The following is a description of a gene set: Deregulation of Ras pathways results in complex abnormalities of multiple signaling cascades that contribute to human malignancies. Ras is therefore considered an appropriate target for cancer therapy. In light of the complexity of the deregulated Ras pathway, it is important to decipher at the molecular level the response of cancer cells to Ras inhibitors that would reregulate it. In the present study, we used gene expression profiling as a robust method for the global dissection of gene expression alterations that resulted from treatment with the Ras inhibitor S-farnesylthiosalicylic acid (FTS; salirasib). Use of a ranking-based procedure, combined with functional analysis and promoter sequence analysis, enabled us to decipher the common and most prominent patterns of the transcriptional response of five different human cancer cell lines to FTS. Remarkably, the analysis identified a distinctive core transcriptional response to FTS that was common to all cancer cell lines tested. This signature fits well to a recently described deregulated Ras pathway signature that predicted sensitivity to FTS. Taken together, these studies provide strong support for the conclusion that FTS specifically reregulates defective Ras pathways in human tumor cells. Ras pathway reregulation by FTS was manifested by repression of E2F-regulated and NF-Y-regulated genes and of the transcription factor FOS (all of which control cell proliferation), repression of survivin expression (which blocks apoptosis), and induction of activating transcription factor-regulated and Bach2-regulated genes (which participate in translation and stress responses). Our results suggest that cancer patients with deregulated Ras pathway tumors might benefit from FTS treatment. Selected genes up-regulated in response to the Ras inhibitor salirasib in a panel of cancer cell lines with constantly active HRAS. studied in species Homo sapiens from publication Blum R, Elkon R, Yaari S, Zundelevich A, Jacob-Hirsch J, Rechavi G, Shamir R, Kloog Y (PMID 17409441) Human Gene Set: BLUM_RESPONSE_TO_SALIRASIB_UP, and this is the list of marker genes: CXCL3, LAPTM4A, EIF5, HYOU1, IL6, RSL24D1, EIF1, MARS1, TESK1, VIM, DPAGT1 (NCBI Gene Id 1799), ZYX, ZPR1, TCEA1, RELB, HOXA1, CASP4, OGT, FST, ULBP1, SCFD1, NSMAF, TOM1L1, PPIE, FEM1B, CD55, TNFAIP3, RAB5A, CSTA, ARHGEF2, YKT6, CDK13, ATF6, TMBIM6, ACVR1, RAD23A, KRT34, SLC35A2, ZNF593, SSR3, CEBPG, LRP1, ERCC1, UBXN1, ISG20, RAB22A, XPC, CCNB1IP1, MGAT1, HSPA9, GADD45A, SEPHS2, NAPG, NAMPT (NCBI Gene Id 10135), COPA, HSPA13, NINJ1, INPP1, BACH1, BAK1 (NCBI Gene Id 578), EIF2S2, NARS1, MDM4, HSP90B1, NOP53, MAP1LC3B, SQSTM1, CSNK1G1, UNG, HMGCL, DNAJA3, TIMM44, EEF2, CBLB, KPNA5, APBA3, SGPL1, PHGDH, AARS1, RELA, RNF7, POLI, STC2, TBL1X, RPL12, UBE2H, CALU, CANX, TOM1, ZFPL1, RAB32, NDEL1, BCL2L1, KCMF1, PSEN1, IFRD1, RIOK3, SLC1A5, STX4, SARS1, EIF4EBP1, CBX4, P4HB, COX7A2L, SERPINB8, SERP1, GOLGA5, GOLGB1, NUPR1, SLC33A1, GOT1, CNIH1, MTHFD2, CDKN1A, NIT1, CTSL (NCBI Gene Id 1514), EIF1B, GLG1 (NCBI Gene Id 2734), TARS1, GFPT1, NFKBIA, SCAMP2, ESRRA, RALA, ATF5, FAM3A, PPP1R11, TMED3, RAB33A, MTIF2, TP53, PPP2R5B (NCBI Gene Id 5526), CTH, RRAGC, STAM2, BCAT1, MKNK2, ENTPD6 (NCBI Gene Id 955), QSOX1, FOSL1, GOSR2 (golgi SNAP receptor complex member 2), TP53BP2, SIAH1, DAP3, XPOT, VPS28, SPHK1, USP3, ECH1, KLF11, SEC63, SIAH2, LIPT1, MYO5A, ERP29, TNFRSF10B, CBS, AVEN, GTPBP2, PSMD8 (NCBI Gene Id 5714), CREB3, COX10, COG5, BTG1, TSG101, TRIB3, STK19, EPRS1, DNAJC1, BUD31, PEA15, CTSD, PSAT1, EIF3H, PKD1, WARS1, TIMM9 (translocase of inner mitochondrial membrane 9), AZI2, CSNK1A1, IL12A, SUPV3L1, ASNS (asparagine synthetase (glutamine-hydrolyzing)), ACBD3, RRN3, MMP10, SURF1, PJA1, ADPRM, MAFG, ARF4, ATF4, NPC1, ATF3, ANXA7, FOXO3, NGF, PTP4A2, ANK2, GALE, MYG1, SUCO, RNF13, MAPK6, SEL1L, DUS4L, PMS2, DNAJB9, SHMT2, CHIC2, PPP1R15A, SKIC2, DCTD, CDK7, SEZ6L2, SNHG32, GOLGA4, ROBO3, BLVRB, GHITM, KPNA4, TIMP1, YIF1A, GARS1, BIRC2, PFDN2, STX5, ELL2, CARS1, RNF14, DDX10, MAFF, IARS1, AP3S2, TBCE, RTCA, COPG1, USP25, PTX3, CLASRP, EGR1, RAD50, MMP1, CSRNP2, XIAP, TSSC4